Given this list of marker genes TTC39C, CXCR6 (NCBI Gene Id 10663), ANKRD28, SATB1, GPX1, FKBP11, PFKFB3, PRDM1, GNA15, ERN1, SNX9, CELF2, HPGD, TNFSF13B, PHACTR2, NINJ1, SPOCK2, ALOX5AP, LST1, CCR6, PERP, TANK (TRAF family member associated NFKB activator), TNFRSF18, KLRB1, RORA, LGALS3, TNFRSF25, JAML, CEBPD, RBPJ, AQP3, CTSH, HOPX, IFI44, NFKBIA, MAF, LTB, FURIN, IL4I1, TMIGD2, IL7R, GPR65, ODF2L, CERK, GPR171, RBMS1, NCR3, IFNGR1, CCL20, GNLY, here is a description of the gene set: studied in species Homo sapiens In this study, an extensive analysis was conducted to define meta-programs (MPs) capturing intra-tumor heterogeneity across a spectrum of tumor types. The approach utilized non-negative matrix factorization (NMF) to analyze each cell type separately within individual tumor samples. This involved the analysis of malignant cells, macrophages, fibroblasts, endothelial cells, epithelial cells, T-cells, and B-cells. NMF was executed with varying parameter values (K=4, 5, 6, 7, 8, 9), thereby generating 39 programs for each cell type per sample. Each NMF program was summarized by the top genes based on NMF coefficients.\nRobust MPs were then delineated for each cell type using a set of stringent criteria, including recurrence within the same tumor, similarity to programs in other tumors, and non-redundancy within a tumor. Subsequently, these robust NMF programs were clustered (per cell type) based on Jaccard similarity, leading to the identification of MPs associated with each cell type.\nTo enhance the quality of the MPs, a refinement steps were undertaken, involving the removal of MPs suspected of reflecting low-quality data (with an overrepresentation of ribosomal proteins or mitochondrial-encoded genes), single-study inclusion, or similarity to miss-annotated cell types. Human Gene Set: GAVISH_3CA_METAPROGRAM_CD8_T_CELLS_NAIVE_3 from publication Gavish A, Tyler M, Greenwald AC, Hoefflin R, Simkin D, Tschernichovsky R, Galili Darnell N, Somech E, Barbolin C, Antman T, Kovarsky D, Barrett T, Gonzalez Castro LN, Halder D, Chanoch-Myers R, Laffy J, Mints M, Wider A, Tal R, Spitzer A, Hara T, Raitses-Gurevich M, Stossel C, Golan T, Tirosh A, Suvà ML, Puram SV, Tirosh I (PMID 37258682) Genes upregulated in subsets of cells of a given type within various tumors